Given this list of marker genes NDUFS2, TBPL1, NDUFB11, CAD, ANTKMT, NUDT2, NDUFB4, ATP5PB, SDHD, IMPDH1, UCK2, ATP5ME, NME9, PRKN, NDUFB9, MT-ND5, PPARA, SDHC, ATP5F1C, ATP5MK, NDUFB10, AK1, ATP5MG, NDUFS4 (NADH:ubiquinone oxidoreductase subunit S4), ATP6V0C, ATP5MF, NME1, NDUFA7, DNAJC30, LETMD1, VPS9D1, NDUFB5, PID1, ADCY10, ADK, ATP5F1B, ENO1, SDHA, AK3, LDHC, ATP5F1A, TYMS, NDUFA10, NDUFA2, ATPSCKMT, IL4, NDUFA9, TGFB1, NDUFV2, NDUFA5, NDUFAB1, NME3, MT-ND2, NDUFA3 (NCBI Gene Id 4696), NDUFV3, ATP5F1E, NME2, MT-ND4L, NDUFA11, NME4, ATP5PO, NDUFB3, ATP5MC2, COX11, UCKL1, ATP5F1D, SDHB, MT-ATP6, NME5, DTYMK (deoxythymidylate kinase), NDUFS7, NDUFB2, ATP5MC3, CTPS1, STOML2, TAFAZZIN, NDUFB7, LIPA, UCK1, NDUFA1, NDUFC2, MT-ND1, MIR675, CMPK2, ATP5MC1, ALDOA, TREM2, NDUFA12, PINK1, STAT3, NME2P1, DMAC2L, TMSB4X, MT-ATP8, MT-ND6, NDUFS1, NDUFA6, NDUFV1, NDUFS5, ATP5PF, NDUFS3, IMPDH2, ATP5MGL, ATP5PD, NDUFS6, SLC25A13, NDUFA8, UQCC3, NME7, MT-ND3, NDUFA13, AK4, NDUFC1, MAP2K1, CTPS2, VCP, PARP1, ATP5IF1, ATP5F1EP2, NDUFS8, NDUFB8, NDUFB6, PRKAG2, FAM3A, NME6, SPHK2, ATP5MJ, MT-ND4, NDUFB1, here is a description of the gene set: studied in species Homo sapiens Human Gene Set: GOBP_NUCLEOSIDE_TRIPHOSPHATE_BIOSYNTHETIC_PROCESS The chemical reactions and pathways resulting in the formation of a nucleoside triphosphate, a compound consisting of a nucleobase linked to a deoxyribose or ribose sugar esterified with triphosphate on the sugar.